Given this list of marker genes Bhmt2, Prmt1, Cmtr1, Eef1akmt4, Ftsj1, Tfb2m, Kmt2c, Mettl18 (NCBI Gene Id 96883), Nsun2, Pcmtd1, Ntmt1, Mrm3, Ndufaf7, Comt, Pcmtd2, Tomt, Alkbh8, Mettl21c, Trmt10c, Ehmt1, Prmt5, Eef2kmt, Setdb2, Setdb1, Nsun3, Fbll1, Trmt10b, Zcchc4, Trmt5, Nsd1, Kmt5b, Nsun5, Carnmt1, Asmt, Cmtr2, Suv39h2 (suppressor of variegation 3-9 2), Mettl16, Mrm1, Dnmt3b, Dnmt1, Dnmt3l, Trmt11, Trmt1l, Mettl14, Mettl4, Mepce, Pnmt, Trmt2b, Trmo, Etfbkmt, Setd5, Ezh1, Ash1l, Setd7, Kmt2b, Pemt, Prmt6, Suv39h1, Mecom, Prmt7, Kmt5a, Smyd5, Prmt3, N6amt1, Comtd1, Prmt2, Carm1, Mettl8, Prdm6, Smyd2, Setd1b, Ash2l, Fdxacb1, Mettl2, Kmt2e, Tgs1, Tfb1m, Mettl21a, Nsd3, Eef1akmt1, Prdm16, Eef1akmt3, Dimt1, Smyd1, Dot1l, As3mt, Ehmt2, Mrm2, Prmt8, Mettl1, Wdr5, Trmt2a, Tmt1b, Antkmt, Prmt9, Mettl23, Fbl, Tmt1a2, Kmt5c, Bud23, Nnmt (nicotinamide N-methyltransferase), Tmt1a, Mettl9, Armt1, Inmt, Setd6 (SET domain containing 6), Mettl13, Setmar, Nop2, Pcmt1, Vcpkmt, Setbp1, Mettl15, Trdmt1, Eef1akmt2, Lcmt1, Gamt, Pcif1, Ndufaf5, Smyd3, Coq3, Ezh2, Prdm9, Ftsj3, Mettl3, Hemk1, Setd3, Rnmt (NCBI Gene Id 67897), Kmt2d, Tpmt, Atpsckmt, Prdm8, Nsun4, Dnmt3a, Mettl5, Jarid2, Setd4, Dph5, Icmt, Gnmt, Kmt2a, Trmt61a, Tmt1a3, Trmt9b, Thumpd2, Tarbp1, Trmt10a, Trmt1, Fbxo11, Nsd2, Thumpd3, Nsun6, Mettl6, Ntmt2, Setd1a, Setd2, Emg1, Camkmt, Hnmt, here is a description of the gene set: studied in species Mus musculus Mouse Gene Set: GOMF_S_ADENOSYLMETHIONINE_DEPENDENT_METHYLTRANSFERASE_ACTIVITY Catalysis of the transfer of a methyl group from S-adenosyl-L-methionine to a substrate.